The following is a description of a gene set: Mouse Gene Set: MIR_133C Genes predicted to be targets of miRBase v22 microRNA mmu_miR_133c in miRDB v6.0 with MirTarget v4 prediction scores > 80 (high confidence targets). from publication Chen Y, Wang X (PMID 31504780) species: Mus musculus, and this is the list of marker genes: Aif1l, Arfip2, Thrap3, Zc3h14, Ankrd12, Cdyl2, Cyria, Ncald, Scyl3, H2-Aa, Sgms2, Sf3b1, Rab30, Dpysl4, Dmxl1, Lancl2, Vat1, Arhgap12, Serpina12, Aldh1a3, Sf3b4, Ric1, Dusp28, Zc3h11a (zinc finger CCCH type containing 11A), Eya1, Fbn1, Otc, Xylb (NCBI Gene Id 235676), Zfp131, Adcyap1, Tmod3, Elfn1, Selenof, Ttyh3, Actr1a, Gpm6a, Agt, D5Ertd579e, Arrb1, Sfxn5, Prrt2, Myrf, Pik3c2a, Dmxl2, Rffl, Med12l, Hs2st1 (heparan sulfate 2-O-sulfotransferase 1), Plekha3, Map4, Acat3, Ppfia1, Rbpj, Ptbp1, Sec61a1, Tfap2d, Foxl2, Sp3, Ppp2ca, Foxp4, Rarb, Cap1, Usp32 (ubiquitin specific peptidase 32), Ago1, Papln, Mmgt1, P2rx4, Sumo1 (NCBI Gene Id 22218), Vps13a, Sgpp1, Tent4b, Rb1cc1, Cul4b, Dhx32 (NCBI Gene Id 98257), Enc1, Kcna6, Gab2, Fam163b, Ppp2r2d (protein phosphatase 2, regulatory subunit B, delta), Vps54, Jazf1, Afap1, Garnl3, Pcgf2, Ankrd44, Ptbp3, Mtmr4, Ebf2, Tbpl1, Hpcal4, Kmt2c, Tpd52l1, Ptpro, Actn4, Phf24, Cmpk1, Mmp15, Fam199x (family with sequence similarity 199, X-linked), Zfp362, Slc25a39, Sacm1l, Adamts5, Lhx5, Prrx1, Edem1, Gatad2a, Virma, Simc1, Syt1, Myh9, Pan3, Ptprz1, Ube2q2, Ppp2cb, Elavl1, Aftph, Yes1, Uba2, Nup153, Csnk1g3 (casein kinase 1, gamma 3), Ankrd28, Emp2, Sh3tc1, Ube2q1, Rbmx, Shisa5, Msn, Btbd3, Rab5c, Sirt1, 2700062C07Rik, Sgk1, Plpp2, Fam117a, Spn, Faim, Grm5, Cacna1b, Peak1, Glra2, Pex5l, Zfp280c, Clta, Irf2, Wasf2, Slc50a1, Xpo1, Fam117b, Slc6a1, Kcnd3, Slc30a7, Fhip2a, Eif4a1, Tfg, Maml1, Snx30, Epha7, Tmem167, Lsp1, Sec61b, Pfn2, Kctd20, Raph1, Cnn2, Fgf1, Lhfpl6, Ctbp2, Dolpp1, Dync1li2, Dnah11, Braf, Timm17a, Celf1, Sephs2 (selenophosphate synthetase 2), Il1rapl2, Gabpb2, Snrk, Fbxl2, Ckap4, Riok2, Acat2, Arhgef9, Col25a1, Cbll1, Arpc5, Bicc1, Arhgap24, Tagln2, Gdnf, Ldlrap1 (low density lipoprotein receptor adaptor protein 1), Tafa5, Tspan15, Celf4, Sh3gl2, Nell2, Nup160, Kat5, Sobp, Dusp1, Mllt3, Fads1, Pax7, Lasp1, Tax1bp1 (Tax1 (human T cell leukemia virus type I) binding protein 1), Rap2c, Praf2, Tent5a, Gabarapl1, Smarcd1, Hsd17b11 (NCBI Gene Id 114664), Sertad4, Pitpnm2, Foxc2